Given this list of marker genes Mus81, Mcm7, Gins4, Mcm3, Mcm6, Gins2, Mcm2, Mcm5, Cdc45, Mcmdc2, Cdc7, Mcm4, here is a description of the gene set: studied in species Mus musculus The error-free repair of a double-strand break in DNA in which the centromere-proximal end of a broken chromosome searches for a homologous region in an intact chromosome. DNA synthesis initiates from the 3' end of the invading DNA strand, using the intact chromosome as the template, and progresses to the end of the chromosome. Mouse Gene Set: GOBP_DOUBLE_STRAND_BREAK_REPAIR_VIA_BREAK_INDUCED_REPLICATION